The following is a description of a gene set: Human Gene Set: MIR1287_3P studied in species Homo sapiens Genes predicted to be targets of miRBase v22 microRNA hsa-miR-1287-3p in miRDB v6.0 with MirTarget v4 prediction scores > 80 (high confidence targets). from publication Chen Y, Wang X (PMID 31504780), and this is the list of marker genes: WDR44, UBA2, KLHL13, GPR183, GNA14, PAK2, DNAJC16, BDKRB2, SORBS1, RNPS1, PDIA3, YEATS4, CENPI, DDX60, ABL2, RAB5A, C2orf68, MACIR, MSN, GJB4, SNAP47, BRWD1, ANKRD61, PTPN9, GPATCH8, AP4S1, SMIM14, RNF6, RNF7, COG3 (component of oligomeric golgi complex 3, NCBI Gene Id 83548), GABRB2, P2RY14, RIC8B, SRP19, CXCR2, SLC1A5